The following is a description of a gene set: Human Gene Set: HP_FETAL_ULTRASOUND_SOFT_MARKER studied in species Homo sapiens An finding upon obstetric ultrasound examination performed at around 16 to 20 weeks of gestation that is abnormal but not clearly identifiable as a fetal anatomic malformation or growth restriction. Such findings are known as soft markers since they are associated with increased risk for fetal aneuploidy or other disorders. Fetal ultrasound soft marker, and this is the list of marker genes: FAT4, TRAF7, CCDC22, HRAS, TBC1D24, PGAP3, SQSTM1, PTPN11, EFNB1, ITPR1, PAK2, ASXL2, PEX6, DPF2, LZTR1, KANSL1, FGF13, ALG9, PSAT1, RIT1, PEX19, PIGV, LRPPRC, MAPT, RNU4ATAC, TBCK (TBC1 domain containing kinase), TLK2, SPECC1L, HSPG2 (NCBI Gene Id 7796), LBR, PEX2, PEX3, LAMA5, ENPP1, QRICH1, PEX12 (peroxisomal biogenesis factor 12), FOXF1, SPRED2, WT1, CLCN3, MYL9, RAC1, SLC30A9, CBL, KRAS, MAX, THSD1, EBP, WNT3, PI4KA, FANCB, VCP, MRPS16, SOS2, PEX5, WASHC5, ZIC3, PIGN, ZBTB18, PSEN1 (NCBI Gene Id 5663), ABCC6, BNC2, PIGA, NUP88, PEX10, MKS1, HNRNPK, PEX1, SOS1, COG8, ZBTB42, MRAS, PEX11B, MYT1L, DOCK11, SLC31A1 (NCBI Gene Id 1317), PIGW, SLC26A2 (NCBI Gene Id 1836), GATA6, MCTP2, FANCF, RASA2, ATP6V1B2, FH, SLC35A2, DPYSL5, PACS1, CACNA1C, ZNF699, POR, FBXL4, PEX16, CAPRIN1, TWIST2, CDC42BPB, TAPT1 (NCBI Gene Id 202018), NRAS, HPS6, PGAP2, VPS35L, MYH7, PEX26 (NCBI Gene Id 55670), PIGO, SCARF2, CHMP2B, PIGL, PEX13, HOXD13, RNU4-2, GRN, TRIP11, KMT2D, TREM2, ADGRG6, RYR3, DDX6, RRAS, PIGY, PEX14, RRAS2, GNB2, KIF26A, STAG1, RAF1, TMEM106B